The following is a description of a gene set: from publication He P, Lim K, Sun D, Pett JP, Jeng Q, Polanski K, Dong Z, Bolt L, Richardson L, Mamanova L, Dabrowska M, Wilbrey-Clark A, Madissoon E, Tuong ZK, Dann E, Suo C, Goh I, Yoshida M, Nikolić MZ, Janes SM, He X, Barker RA, Teichmann SA, Marioni JC, Meyer KB, Rawlins EL (PMID 36493756) Early cap studied in species Homo sapiens Human Gene Set: HE_LIM_SUN_FETAL_LUNG_C3_EARLY_CAP_CELL, and this is the list of marker genes: CHCHD6 (coiled-coil-helix-coiled-coil-helix domain containing 6), MIR3667HG, PBX3, NCAPG, NAMPT, PSAT1, CDCA3, MAP7D3, RFC4, LRWD1, SNHG32, RIN1, SPAAR, BNIP1, DUSP3, CDCA7, PNO1, HRH1, CACNB3, ERRFI1, HIC1, DISC1, ZWINT, NUDT1, THY1, GOLM1, HEBP2, DEAF1, CKS1B, STMN3, RGS14, TEAD4, MAPK12, CEACAM21, FH, ZCCHC3, PRTG, UBALD2, FAM110D, SKA2, PCBP4, HPRT1, C8orf58, TEDC1, FOXM1, LONRF1, TLE2, GPX8, MPI, CEBPB, NOX4, PDLIM2, H1-1, LCA5, CIP2A, C11orf96, FBXO5, GMPPB, NOSTRIN, UTP18, DIAPH3, CYRIB, FKBP5, C6orf136, MTHFD1, ATAD3A, GAMT, BAALC, TOR2A, BYSL, KIF20B (NCBI Gene Id 9585), SPATC1L, SNAPC1, NOL4L, NUDT15, NPW, PUM3, WDR5, ITGAE, ASF1B, RBM18, PUS1, NUAK2, TTLL12, TSR1, PSMC3IP, PRND, CA2, ACOT7, XKR8, MEX3A, GPSM3, FDXR, PFKP, SNAI2, MTA3, RCC1L, C12orf75, H1-3, PHF19, CENPN, HES6, ATAD3B, PDF, LGALSL, FANCI, SLC12A5, HNRNPA1L3, EIF2B2, NPAS2, ZWILCH, FLAD1, CHAF1A, TMEFF1, THOC6, EXOSC7, SDHAF3, HIPK2, ZNF622, TPX2, MAFB, CDR2L, RARB (retinoic acid receptor beta), H2AC11, CCNA2, MTHFD1L, ARRDC3, FBXO17, PSRC1, SMCO4, SMC2 (NCBI Gene Id 10592), SFXN4, ARHGAP4, PJA1, HMGA2, SLC25A26, SPDL1, LIG3, DONSON, IL4R, TMEM97, GTPBP8, RRM1, KRT10-AS1, GRB10, USP5, CDIP1, TMEM176A, PHGDH, TARBP2, P3H3, H2AC13, PKMYT1, FLYWCH2, PRTFDC1, IFT22, FADS1, PSMD14, COPG2, PAICS, MID1IP1, NAB2, C12orf76, NIPSNAP1, CDK1, NR2F6, APLN, TMCC3, PGAM4, UBE2T, IER5L (NCBI Gene Id 445576), HADH, GMNN, ABL2, RPS6KA1, VEGFA (NCBI Gene Id 7422), P4HA1, NUSAP1, MCAT, RAC2, CENPH, NCKIPSD, ATP1B1, RUVBL1, CCN2, PEX14, CLSPN, HDGFL2, HIP1R, LIPG, CCNB1, EGFLAM, IGF2BP1, YARS1, DENND3, TAGLN3, FEZ1, SLC25A22, NCAPH, JMJD6, TRAF4, SPRYD4, RDH13, MRPS27, ROBO1, LDLRAP1, ACAT2, SERINC2, TEX30, EMC9, MTHFD2, KCNQ1OT1, CCN1, TACC3, RBPMS2, CENPU, MCM5, GPR161, TDP1, AIMP2, GTSE1, SORD, RELT, MND1, SLC5A6, LEF1, ATIC, PREP, IFFO1, PLAGL1, PACSIN3 (NCBI Gene Id 51165), TMED3, NDUFAF4, ACOT9, VRK1, PHACTR1, ASB1, PBK, FAM136A, ARHGAP10, PMAIP1, FAM43A, TUBB3, PAQR4 (NCBI Gene Id 124222), GRK5 (G protein-coupled receptor kinase 5), SYT1 (synaptotagmin 1), KIF2C, MZT1, ZNF346, ZNF771, EXOSC5, TCF15, TIMELESS, TMEM243 (NCBI Gene Id 79161), RFC5, KDM1A, ENAH, CCDC9, CDH13, UBE2S, MACROH2A2, HS6ST1, XIST, MXI1, TMEM176B, IER3, TMEM51, CCDC112, H2AC20, PFKM, RNASEH1, PPP1R35, TLE3, CISD3 (CDGSH iron sulfur domain 3), BCAT1, SIGMAR1, KRT8, MCM4, CDKN3, ZFAND2A, TK1, MRPL49, STRA6, NUP93, DCPS, TBRG4, INSIG2, FAM13A, RAB34, ADISSP, NTMT1, ID2, MCM2, NDFIP2, MLLT11, TP53RK, NPM3, PPP1R14B, CENPE, CENPW, SGTA, MYC, NEURL1B, PTGR1, LYAR, POC1A, RFC2, ALG3, RNF113A, MGST1 (NCBI Gene Id 4257), GATB, ST3GAL4, SPINDOC, PRIM2, WARS2, KIF4A, DHFR, EIF2B3, PRR3, CTSC, SAAL1, TMEM161A, PELO, HACD1, MADCAM1, KIF20A, UNC119, CENPK, KNSTRN, ORAI1, REC8, RARG, COL15A1, GTPBP3, RPUSD3, ZC3HC1, HRAS, NELFA, UBL4A, ATAD2, KIFC1, MYLK2, MLKL, HGH1, SNAI1, EBP, MVD, AMPD2, RIPK2, FAM78A, AKIP1, CMSS1, TMC6 (transmembrane channel like 6), ARFIP2, AK4, HMGN5, RANGAP1, KCNQ1, HAPLN1, ATP6V0E2, ETV4 (ETS variant transcription factor 4), RHOBTB3, SLC25A33, ACOT13, TLCD3A, CDK5RAP1, FAM162B, SPOCK2, DCAF15, PHF23, DUSP4, LDAF1, CCNQ, ALYREF, GIPC1, C19orf48P, USP18, PPIF, PLCXD1, CTXN1, RRAS2, RRP15, BIRC5, UQCRHL, RASGRP2, HMMR, H2AC25, GINS2, ASB9, SLC16A14, POLR1E, H2BC9, SLC25A4, FBLN1, EDIL3, SLC2A6, GPATCH4, IL13RA1, RHNO1, UBE2M, NARS2 (asparaginyl-tRNA synthetase 2, mitochondrial), CLDN7, METTL1, ADORA2A, SMIM10, CHCHD4, NCLN, CLEC11A, SIPA1L2, CELF2 (NCBI Gene Id 10659), ANP32E, CFP, DUSP5, CDC20, CENPF, TYRO3 (TYRO3 protein tyrosine kinase), NHERF1, TTC9C, ALDH7A1, ZNF581, APBA2, SLC16A3, ALG8, PAWR, BOP1, MMD, POLR3D, MYO10, IGFBP3, KPNA2, POLR1A, PYCR1 (pyrroline-5-carboxylate reductase 1), WDR12, STC2, ORC6, TIMM9, DOLPP1, FARSB, ADA, MPHOSPH6, SLC35G1, MRPL10, SERPINE1 (NCBI Gene Id 5054), ZNF579, KLHDC8B, WASF1, MIX23, PLOD2, OIT3, NOP14, NAGA, PCDH1, RTCA, LIG1, KIF22, CENPM, PGP, IFITM1, LMNB1, TNFRSF10A, RAB32, UCP1, DYNLT5, NNAT, NQO1, MCM6, LRR1, MCC, C1QTNF6, SLC16A1, SMAD6, NDUFAF2, SNX24, LMO7, HAUS4, PCAT14, LRCH4, CHEK1, PUSL1, NLE1, SIK1, BCAT2, RGS19, ARMT1, MYBL2, RCBTB2, MKI67, ABCA1 (NCBI Gene Id 8371), RCC1 (regulator of chromosome condensation 1), CHN1, RAD51AP1, GNL2, MAG, AVEN, HOXB4, ERCC2, HSPA6, DLGAP5, CDCA7L, HOXB2, MAPK11, NAA15, MRGBP, FAM210A, RARA-AS1, AAAS, H4C11, MRPL39, THOP1, HSD17B14, TMSB15A, MMAB, BCL3, EZH2, CDH8, TMEM237, LINC01082, TMEM37, CCNB1IP1, MMP1, LRP5L, UHRF1, BAMBI, NUP37, DTNB, TRABD, EVA1B, CENPV, RPL39L, NSMCE2, EFCAB11, CTU2, MVK, ZNF219, CBR1, BCL2L12, TEX10, LMNB2, BASP1, GRWD1, PLEKHO1, MARK4, ANGPTL4, DEF8, PDLIM4, MARVELD1, DOK4, RMI2, TPM2, CDT1, CKS2, RNF2, PRRT2, RNASET2, F2R, GGH, PCNA, SELENOM, PLK1, SMYD3 (SET and MYND domain containing 3), ARID3A, TMEM69, CD24, DDX11, TMEM106C (transmembrane protein 106C), SNHG12, DHCR7, QPCT, ICAM1, RNASEH1-DT, CREG2, SLC19A1, RRP9, PACC1, CD70, CYP26B1, FKBP1C, CTPS1, ECHDC3, CMTM8, NDUFAF6, MIPOL1, XRCC1, PCLAF, DHCR24, EXOSC2, H2AC14, STC1, RNF144B, RANGRF, GNL3, TYMS, CDC42EP3, ERO1A, TRIP13, NCAPD2, CDCA5, PTTG1, MAD2L1, GATA3, ANAPC15, PTGES2, CCDC86, USP39, PVR, COQ5, NUP88 (NCBI Gene Id 4927), CXXC5, FAM216A, TUBB2B, THBS1, WIPI1, UCK2, CXCR4, TOP2A, KCNK6, AURKB, MBOAT7, HDHD5, PDCL3, YARS2 (tyrosyl-tRNA synthetase 2), CDC42EP4, CCDC34, FANCG, TCOF1, FASN, MTFP1, ULBP1, JPH1, UBE2C, SPATS2L, DALRD3, RNF24, MRRF, SFXN1, UPP1, SNHG19, LHX6, CLGN, CDK2, GMDS, RAC3, CYP2S1, CCNB2, NAT14, SNRNP25, AIFM1, WDR25, SLX9 (SLX9 ribosome biogenesis factor), FOSL2, USB1, TFAP4, GFER, BCOR, CCDC85C (NCBI Gene Id 64758), RIOK1, NEK6, DCBLD1, PIMREG, ZNF593, UCHL1, PPIL1, FAM229B, GTPBP4, HOXA4, H2AC8, HILPDA, HNRNPA1L2, ACYP1, UBXN8